The following is a description of a gene set: Human Gene Set: HEIDENBLAD_AMPLICON_8Q24_DN species: Homo sapiens from publication Heidenblad M, Lindgren D, Veltman JA, Jonson T, Mahlamäki EH, Gorunova L, van Kessel AG, Schoenmakers EF, Höglund M (PMID 15688027) DNA copy number alterations are believed to play a major role in the development and progression of human neoplasms. Although most of these genomic imbalances have been associated with dysregulation of individual genes, their large-scale transcriptional consequences remain unclear. Pancreatic carcinomas frequently display gene copy number variation of entire chromosomes as well as of chromosomal subregions. These changes range from homozygous deletions to high-level amplifications and are believed to constitute key genetic alterations in the cellular transformation of this tumor type. To investigate the transcriptional consequences of the most drastic genomic changes, that is, genomic amplifications, and to analyse the genome-wide transcriptional effects of DNA copy number changes, we performed expression profiling of 29 pancreatic carcinoma cell lines and compared the results with matching genomic profiling data. We show that a strong association between DNA copy numbers and mRNA expression levels is present in pancreatic cancer, and demonstrate that as much as 60% of the genes within highly amplified genomic regions display associated overexpression. Consequently, we identified 67 recurrently overexpressed genes located in seven precisely mapped commonly amplified regions. The presented findings indicate that more than one putative target gene may be of importance in most pancreatic cancer amplicons. Down-regulated genes whose expression is associated with amplification of the 8q24 chromosome region in pancreatic cancer cell lines., and this is the list of marker genes: NT5C2, SLC14A1 (NCBI Gene Id 6563), MYOF, MYL12A, ATF4, ADAM8, COMMD6, XRCC1, CNKSR3, TULP4, SEC63, MMRN2, NEK6, HIVEP3, NAB1, SAP18, VAPA, RAE1, SRSF11, SLC9A8, KCNN4, GSTK1, RABEPK, CFHR1, IRAK3, HPS1, TMEM242, LAPTM5, NAPG, GPC1, ETHE1, PYROXD2 (NCBI Gene Id 84795), FLG, LPP, FZD4, NT5DC1, MDK, RBM33, PRICKLE1